Given this list of marker genes TSGA10, IPO13, B4GALNT1 (NCBI Gene Id 550623), SLC16A9, IFNG, ATF4, UBE2E3, ZFP41, GLMN, CXCR3, WAPL, VEZT, STARD6, STT3A, PLAAT3, ADORA2B, TSPAN4, DUSP16, LTK, IL10, ARID5A, IARS1, AHRR, F2R, TMEM165, PSMA3, MEGF9, SLC66A2, VPS29, PLAC8, TBX21, KLRG1, NFATC1, SCO1, TGFB3, EYA3, EIF3A (NCBI Gene Id 8661), TTC39C, GZMA, BRINP3, AHR, DSG2, DAD1, CD8B, MTHFS, SDHAF2, FHL5, ELL2, DUSP14, LHX3, CABLES1, MPZL2, MORN4 (MORN repeat containing 4), SKAP2, HOOK1, KLRK1, SH3BP2, RNPEP, PRXL2A, NCAPG, IL4, C12orf75, LACC1, PAFAH1B1, HBG2, ACP3, GABARAPL1, SDF2L1, VMP1 (vacuole membrane protein 1), RRBP1, CENPK, SULT2B1, LPAR3, SMYD3, PIM2, LPIN2, VARS1, KDELR2 (KDEL endoplasmic reticulum protein retention receptor 2), CPZ, CARD10, UBR5, EHD1, CATSPERD, BARD1, MGAT1, PKD2, OSGIN1, IL12RB2, VKORC1, HIC1, PTPN3, EXOSC8, PRSS16, PDE3B, SUV39H2, EIF2S2, RABL3, CDYL2, ATF3, KLHL40, PLIN2, FRMD4B, ENPP1, AGFG1, IL2RB, STRA8, IRF8, CCDC112, APRT, SSR4, SMIM3, CEBPB, PPP1R16B, FPGS, DESI1, NPLOC4, BCL2A1, IFIT1B, TRMT10A, GADD45B (growth arrest and DNA damage inducible beta), ADCY5, LGALS3, SLC30A2, SEC61G, UTY, SLC39A4, PUS3, RPS6KA6, CD38, SUSD3, KLRD1, CD70, MED30, ATP6V0E2 (ATPase H+ transporting V0 subunit e2), NUCB1, CCN4, RAD23B, SLC25A13, ZNF770, NKG7, BTG3, CHST11, CHORDC1, NOTCH1, NEU3, RIF1, SEC61B (SEC61 translocon subunit beta), MARVELD2, MFSD6, GABRR1, EPHB6, PSMA5, RSPH1, UBE2T, GEMIN8, CHPT1, BCAT1, NEDD4, RBPJ, GIMAP7, POMP, GJB1, MED7, RYK, CRLF1, RUNX2, PRDM1, SRGN, SUGT1, DUSP19, FASLG, HSPA1B, VCPIP1, GRB2, SLA2, LRRC1, LITAF, CASP3, FHL2, TSPAN3, DDX3Y, KNL1, ZC2HC1A, DCLRE1B (NCBI Gene Id 64858), CD8A, PDCD1, POLE2, MLEC, ZCCHC3, ITPRIPL2, TAF2, CPD, RIOX1, NAA20, CLTC, PYCR1, KDM5D, GKAP1, TRABD, CLDN12, here is a description of the gene set: The transcription factor Foxp3 is usually considered the master regulator for the CD4+CD25+ studied in species Homo sapiens Genes up-regulated in comparsion of sfActCD4TGF versus ActCD4TGF (see Fig. 1 in the paper for details). Human Gene Set: GSE7460_FOXP3_MUT_VS_WT_ACT_WITH_TGFB_TCONV_UP from publication Hill JA, Feuerer M, Tash K, Haxhinasto S, Perez J, Melamed R, Mathis D, Benoist C (PMID 18024188)